Given this list of marker genes ENSG00000274276, GUCY1B1, THAP4, CBS, GSTP1, here is a description of the gene set: studied in species Homo sapiens Human Gene Set: GOMF_NITRIC_OXIDE_BINDING Binding to nitric oxide (NO).